Given this list of marker genes RPTOR (regulatory associated protein of MTOR complex 1), TSC2, TELO2, RHEB, TTI1, AKT1S1 (NCBI Gene Id 84335), TSC1, TBC1D7, MTOR, DEPTOR, MLST8, here is a description of the gene set: species: Homo sapiens Pathway Definition from KEGG: (TSC1+TSC2+TBC1D7) -| RHEB -> mTORC1 TSC1/2-mTORC1 signaling pathway. Pathway ID: N01575. Pathway type: Reference. Pathway class: nt06522 mTOR signaling. Human Gene Set: KEGG_MEDICUS_REFERENCE_TSC1_2_MTORC1_SIGNALING_PATHWAY